Given this list of marker genes PSMD11, AP2A2, VCL (vinculin), KPNB1, HBB, HSPA1A, DDX3X, PTPRN2, ARPC5, GAA, DYNLL1, PSMB1, ACTR10, PSMD12, DSP, LAMP1, APEH, CFD (complement factor D), PSMA2, NFASC, CD55 (NCBI Gene Id 1604), SLC2A3, FCN1, PNP, SERPINB6, ALOX5, CANT1, CALML5, SIGLEC5, EEF1A1, ATP6V0A1, NME2, SERPINB12, CLEC4C, SERPINB10, COMMD9, DERA, CTSD, KCMF1, VCP, AGL, ITGAX, PPIA, GSN, PSMC3, DYNLT1, CTSZ, SERPINA1, C1orf35 (NCBI Gene Id 79169), A1BG, CSNK2B, GNS, GUSB, HSPA6, APAF1, RAC1, AMPD3, PYGL, PSMD6, HSP90AB1, HSP90AA1, CAB39, CAND1, LGALS3, JUP, PLEKHO2, DSG1, TBC1D10C, TIMP2, YPEL5, XRCC6, GMFG, DBNL, ILF2, ALDOA (NCBI Gene Id 226), PDAP1, QPCT, PPIE, HSPA1B, LILRA3, ACTR1B, PKM, GSDMD, SIGLEC14, MAPK1, CSTB, FCER1G, NCKAP1L, ENPP4 (ectonucleotide pyrophosphatase/phosphodiesterase 4), BIN2, CAT, PRDX4, UBR4, CCT8, LTA4H, MVP, ITGB2, TCIRG1, FPR2, LAMTOR1, VPS35L, MMP9, ARSB, PSMA5, PRCP, IMPDH1, PFKL, MAPK14, PSMC2, RHOA, DIAPH1, MGAM, GLB1, PGAM1, OSTF1, PGM2, MNDA, EEF2, DOK3 (NCBI Gene Id 79930), CTSH, SLC11A1, TNFAIP6, CDK13, PSMB7, STBD1, ATG7, ATP6V0C, CTSS, ACLY, CDA, PSMD2, PKP1, ADAM8, GYG1 (glycogenin 1), DSC1, ATP6AP2, HUWE1, MIF, HSPA8, PGM1, ARL8A, DYNC1LI1, GSTP1, ADGRE3, NBEAL2 (NCBI Gene Id 23218), CAPN1, FCAR, FTH1, GPI, FPR1, PRG2, PAFAH1B2, PSMD14, COTL1 (NCBI Gene Id 90755), FGL2, LAMP2, TMEM179B, SRP14, PSMD13, COMMD3, PSMD7, IDH1, CD58, CRISPLD2, ASAH1, TRPM2, CD93 (CD93 molecule), HMGB1, ALDOC, HK3, CLEC4D, CR1, LILRB2, ALAD, PSMD3, LRG1, CD300A, SIRPA, COPB1, ATAD3B, CST3, ACTR2, IMPDH2, CTSB, KRT1, here is a description of the gene set: Highly exocytosable gelatinase-poor granules found in neutrophils and rich in ficolin-1. Ficolin-1 is released from neutrophil granules by stimulation with fMLP or PMA, and the majority becomes associated with the surface membrane of the cells and can be detected by flow cytometry. studied in species Homo sapiens Human Gene Set: GOCC_FICOLIN_1_RICH_GRANULE